The following is a description of a gene set: species: Homo sapiens Human Gene Set: GSE24102_GRANULOCYSTIC_MDSC_VS_NEUTROPHIL_DN Myeloid derived suppressor cells (MDSC) playing the immune suppressive roles in tumor bearing host consists of two major subsets of granulocytic and monocytic cells. Granulocytic MDSC (G-MDSC) express CD11b+ Gr-1high Ly6G+ Ly6Clow and produce high level of reactive oxygen species (ROS). Interestingly, neutrophils are well known ROS producing cells during immune defensive process and share same surface markers with G-MDSC. These similar features always brought the fundamental questions what’s the difference between G-MDSC and neutrophils but it’s not yet proven clearly. In this study, we examined the gene expression of G-MDSC and neutrophils using Affymetrix microarray. from publication Youn JI, Collazo M, Shalova IN, Biswas SK, Gabrilovich DI (PMID 21954284) Genes down-regulated in comparison of granulocytic myeloid derived suppressor cells (MDSC) versus neutrophils., and this is the list of marker genes: SLAMF8, EIF1AX, CHCHD4, BMP2, TNIP1, RBM19, RHOC, NFKBIE, PRPF31, OLFM1, ATP2A2, TSR2, NOP9, CD74, GASK1B, RPP14, TARS1, AK1, POP7, FN1, IRAK2, GCH1 (NCBI Gene Id 93984), GNB4, DBI, RASGRP1, PTGES3, ZFYVE21, UTP6, TAF9B, B3GALT6, HLA-DQA1, PYCR3, PARP1, YIF1B, UBTD2, SET, ADGRE1, POP1, FYTTD1, SUMF2, CD160, MED28, ENO4, BAG3, BCL2L2, WDR74, B4GALT5, MCOLN2, ANKH, QNG1, WDR83OS, ARV1, DPP6, PLEKHO1, SEC23B, GLRX5, IL1A (NCBI Gene Id 3552), NCS1, SYCP3, EEF1G, NUDT17, TRMT61A, NAGK, RRP9, CRHR1, CAPN2 (calpain 2), NOLC1, GAS6, PSMC2, EGLN3, TMEM186, CXCL2, MRPS18B, PPIE, SLC7A8, MIX23 (NCBI Gene Id 131076), C11orf86, SNX7, ZFP14, MRPL39, TIMP1, APOC3, ECE1, CHID1, MTDH, ATPAF2, SLC39A1 (solute carrier family 39 member 1), PSMB4, PRDM1, OR2T33, TMEM169, VPS50, ZNF471, FPR3, ASPA, DDX21, ROMO1, PDIA6, HS3ST3B1, YBX3, GTF2H2, KIFC3 (NCBI Gene Id 3801), DNAJC10, S100A10, RFTN1, C3orf70, MDFIC, TFEC, EHD2, MICU3, NAB2, CYFIP1, TBL3, MIR22HG, SLC7A7, SQLE, MYCL, BASP1, EIF3I, MET, DNAJA3, EXOSC1, CXCL11, TXNL1, DNAJC21, SRM, SPRY1, GNL3, CHSY3, MFHAS1, IFT22, NUP43, HSPE1, REXO2, CSRNP1 (cysteine and serine rich nuclear protein 1), EIF4G1, SLAMF9, SNX8, RNASE3, WDR43, HIF1A, TMEM176A, HS6ST1, SACS, CD99, HSD17B12, BIK, ST13, NAAA (NCBI Gene Id 27163), STX4, MST1R, EIF3G, TTLL12, RRAS2, TUBB2B, SLC12A4, E2F6, CLEC10A, NAA38, SLC15A3, KCNA5, SPRYD4, RPS8, FGFR1, TMCC3, TRIM13 (tripartite motif containing 13), FAM86B2, TMED9, MARCO, RRS1, BLVRA, MRPL35, FASTKD2, CYP17A1, IL27RA, MYBPC1, PSMC5, DTX2, PIK3AP1, LGALS1, MYO1E (NCBI Gene Id 4643), NHP2, TMEM41A, HOXA3, SKIC8, TRIM28, ADARB1, HSPBP1, SRXN1, NOL12, MYOF, ADO, LUC7L, C8B, SLC25A13, POP5 (NCBI Gene Id 51367), RITA1, PPP1R7, NFKBIB, CDK4